Given this list of marker genes FAS, CARD10, MMEL1, IKBKG, POU2AF1, GTF2H5, POMP, STIM1, SEC61A1, FASLG (NCBI Gene Id 356), IRF5, OTULIN, IL12RB1, IRF1, PSMB8, PGM3 (NCBI Gene Id 5238), CD40LG, IL7R, CASP10, CCND1, WAS, PDCD1, RASGRP1, STING1, TNPO3, MVK, SPIB, CD247, NLRP1, IL12A, ARPC5, TNFSF15, here is a description of the gene set: Human Gene Set: HP_INCREASED_CIRCULATING_IGA_CONCENTRATION species: Homo sapiens Increased circulating IgA concentration An abnormally increased level of immunoglobulin A in blood.